The following is a description of a gene set: Any process that activates or increases the frequency, rate or extent of the chemical reactions and pathways involving a protein. Human Gene Set: GOBP_POSITIVE_REGULATION_OF_PROTEIN_METABOLIC_PROCESS species: Homo sapiens, and this is the list of marker genes: SH3D19, INHBA, SIRT1, HECTD1, RCHY1, FLOT1, C3, IL17D, PTPN1, RASSF5, ADAM9, PDCD10, PRR16, ADCYAP1, BAD, UCN, CDK5RAP1, FASTKD3, CARD9, SENP2 (SUMO specific peptidase 2), SLC25A37, SGSM3, BCL3, DDRGK1, EFNA1, RNFT1, PRELID1, CCNY, SH3BGRL, CDK5RAP3, TBC1D7, DIP2B, TENT5B (terminal nucleotidyltransferase 5B), PSMC5, LRP2, VCP, CAV1, CENPE, PTPN22, BIRC3, MAD2L2, BBS7, TNFSF15, DAB2, RNF41, APOE, CCL19, BARD1, IL1B, NFE2L2, AURKAIP1, ZNF268, EREG, SOCS4, LCP2, CDKN1A, DCUN1D2, EEF2, RBM4, PPIA (NCBI Gene Id 5478), KCNE2, ENO1, SLC51B, AKTIP, PROM2 (prominin 2), LACRT, COPS8, PRMT1, HSPA1B, ATG7, NGRN, DDR2, PRLR (NCBI Gene Id 5618), CDC20B, CSNK1D, PARP14, LPCAT1, ADIPOQ, SOX9, TNP2, SPRTN (SprT-like N-terminal domain), CSNK2A3, SNX1, ZER1, KDR, DIRAS1 (DIRAS family GTPase 1), VPS35, DAOA, BMAL1, RPS6KB2, USP16, FBXW8 (F-box and WD repeat domain containing 8), RAB7A, CTIF, RNF139 (ring finger protein 139), ENPP2, SNF8, MAP2K5, DAZ2, PSMD10, EIF4G1, DIP2A, KLKB1, CCL5, DNAJC3, COMMD1, CLSPN, PLD1, SMAD7, GGA1, ECSCR, FGFR1, METTL8, CREBRF, FXR1, EIF3E, MAP2K2, CAB39, AGO2, PXYLP1, TCIM (transcriptional and immune response regulator), METTL3, ABI1, RANBP9, DAZ3, KEAP1, PRICKLE1, TRAF6, NEK10 (NIMA related kinase 10), IL23R, OTUD6B, BARHL2, RSPO1, UPF3B, MAP3K4, JTB, PSEN1, ATP5IF1, RALB, IL21, RMND1, PIK3CG, TLR9, PIK3C3, FGFR3, RNF185, LDB1, DHX36, FAF1, VPS11, MAP2K1, BIRC7, ITCH, NCSTN, TNFRSF10A, USP13, ANGPT1, DTL, CSF1R, TNP1, CHFR, PTEN, PDCD6, MMP9, EGF, CIB1, VEGFB, ABCF1, SEC22B, STUB1, DHX29, KAT5, RASSF2, CTSC, ZCCHC4, MMD, PAXIP1, PIAS1, COP1, CNTN2, GCLC (NCBI Gene Id 2729), NLRC4, NSMCE3, SUMO2, MUL1, PICALM, APC, APP, SOCS5, TENM1, PLAUR, RAPGEF2, IFNGR1, PLK1, LIN28A, PAWR, ABCG1, SPSB4, ADAM8, PPP1R15A, FANCM, RAP2A, RIPK1, IL15, CACUL1 (NCBI Gene Id 143384), S1PR2, PSMC4, IDE, DAB2IP, ATXN3, CCR7, RIPK3, MAP3K7, SNX33, GBA1, CLU (NCBI Gene Id 1191), UBE2C, FBN1, TBC1D10A, EGLN2, CASS4, CCDC88A, MAGEC2, FBXL5, TARBP2, PLK2, NCK2, RNF111, PYM1, STOX1, UBE2D1, SIRT2, PLGRKT, DRD4, PDGFRB, TMEM259, EZR, LRRTM3, TIFAB, MARCHF7, MAPK9, CLN6, UBQLN2, SYAP1, CDKN1B, SMURF1, DVL1, DDX3X, LTF, MIF4GD, PHF23, RAB3GAP1, CTNNB1, OAZ3, ELAVL1, HSP90AA1, SERPINB3, SLC6A9, FOXO1, SOX17, FBXO33, IFNG, ZFAND2A, SORL1, PPP2R3A, CENPS, TANK, PINK1, CARD14, PIWIL2, KLF2, PIK3R5, KDM1A, STX5, BCL10, ERCC6, UBA2 (NCBI Gene Id 10054), TPD52L1, TNFAIP3, CBFA2T3, FBH1, RDX, MPV17L2, PABIR1, AGER, PASK, EFNA5, SPON1, UBE2K, CEBPA, CLIP3, MTA1, PTK2B, TNF, USP8, YBX3, TNFRSF1B, OGT, STK4, EIF2B5, FMR1 (NCBI Gene Id 5421), FZR1, MIR15B, ARL2BP, CREBL2, PRKDC, CARD10, ITGB1BP1 (integrin subunit beta 1 binding protein 1), TCF7L2, TBX1, MTPN, LILRA2, CPEB3, CHI3L1, DISC1, LIMCH1, TRUB2, NMI, RIPK2, EZH2, NEURL3, SAMD4A, PERP, TRMT10C, CALCA, NEDD4, RELA (NCBI Gene Id 5970), PCSK9, CD28 (NCBI Gene Id 940), IST1, PSMC2, MIURF, HPN, BIRC8, RBM3 (RNA binding motif protein 3), PDGFA, LARP4B, WNT5A, SP1, JAK2, CSNK1A1, IL33, SYK, MT3, MDM2, METTL14, STK11, CSNK2A1, EGR1 (early growth response 1), HDAC2, RAB3GAP2, ASPH, SVIP (small VCP interacting protein), MIR16-1, XIAP, NOP53, ISL1, IL11, BOLL, NDFIP1, DAZ1, PSMC1, VPS28, IL23A, SPRY2, MBP, AIMP2, PIBF1, PSMC3, MST1R, FANCI, BMP2, RAP1A, TNFSF12, FGFR4, PYHIN1, THPO, SEMG2, SEMA4D, PARP9, RHBDD3, IL6, LYN, LRRK2, AMER1 (NCBI Gene Id 160176), PTPRC, IL17F (NCBI Gene Id 112744), L3MBTL3, NKD1, OSM, BRAF, ARNT, ACVR2A, RAD23A, BAK1, CLEC3B, ARRDC3, FGF10, HSPA5, RAF1, SUMO1, PIAS4, MELTF, PCIF1, XBP1, CDC20, TRAF7, GSAP, TGFB1I1, C1QBP, ATG14, PLXNB2, CHRNA7, UPF3A, CBLB, HERPUD1, PLK3, HDAC4, PTK2, FGF18, HNRNPU, MYCBP2, S100A12, CDKN2A, RNF128, RARRES2, AKT2, BMP4, ANXA2, DDA1, CRIPTO, TNFRSF18, POLDIP3, USP5, EIF5A2, GAS6, FAM20A, EIF5AL1, SMYD5, UHMK1, EPHA4, GABARAP, GNL3, BMI1, PKP1, ABCB10, UBQLN1, CCBE1, FAM161A, THBS4, RALBP1 (ralA binding protein 1), GSK3A, CENPX, CR1, NRDC, HABP4, ARHGEF5, DOK7, FBXO4, PEF1, GRN, FXR2, SPDYA, PIK3R6, SEPTIN4, ZC3H12A, PSMC6, AGBL4, LAT, CD74, KIF14, OAZ1 (ornithine decarboxylase antizyme 1), MARCHF2, DCUN1D3, TLR6, RWDD3, SLC2A10, VIP, FLT1, C4BPA, MIR181B1, TRIB3, FASTKD2, MAPK8, PIAS3, TRIB1, RPUSD3, RAMP1, NIBAN1, EGFR, HUWE1, ARRDC4, BANK1, ELOB, SH3RF1, IER3, TNFRSF10B, IL31RA, RCC1L, PLA2G10, TSPYL5, CSDE1, ARAF, DCUN1D4, DERL1, ASTL, RPS6KB1, ADCY8, PFN2, CD4, RASSF1, DHX9, ERBB2, HDAC3, YTHDF2, CRY1, PIM1, LEP (NCBI Gene Id 3952), PAIP1, NUB1, SNX9, CUL4A, ENSG00000293600, SRCIN1, RPUSD4, AURKA, BCAP31, ETAA1, NSF, DCUN1D1, TIPARP, IL12A, RHBDD1, NDUFA13, NAT10, PABPC1, POLR2G, WFS1 (NCBI Gene Id 94141), MAP2K3, FAM107A (NCBI Gene Id 50803), SKP2, SPHK1, RAC1, PILRB, FLT4, DAZ4, FAXDC2 (fatty acid hydroxylase domain containing 2), EFNA3, ITGA2 (NCBI Gene Id 3673), MSN, WDFY2, MIR206, ZFP91, UNC119, INAVA, ABCA2, TAF1 (NCBI Gene Id 6872), NOD2, TOLLIP, SH3RF3, ARHGEF2, CHP1, NCK1 (NCBI Gene Id 4690), TRIM6, CSF1, AXIN1, SYNCRIP, CAPN3, RIGI, FBXW7, FURIN, NUPR1, TRIM67, BRMS1, IFNL1, LARP4, RASD2, FGF1, LILRA5, FGF2, ASB9, OAZ2 (ornithine decarboxylase antizyme 2), MAP3K11, ABL1, RGMA, TNFSF18, DIPK2A, AXIN2, THBS1, CAMK1, MTOR, PRKN, KNDC1, MYDGF, WNT7A, MAP3K5, HLA-DRB1, CCL21, PKM, BTRC, RCN3, CUL3, BAG6, PLCB1, TMX1, IRGM, ROCK2, CAV3, ADRA2A, RPL26, CIRBP, DET1, CCDC22, PRKCD, CNTF (NCBI Gene Id 1270), ITLN1, EIF4G3, UBE3A, PIN1 (peptidylprolyl cis/trans isomerase, NIMA-interacting 1), DNAJA3, YTHDF3, CD81, FBXO22 (F-box protein 22), MMD2, PAQR3, SH3RF2, CSPG4, UBXN2A, RBMS3, NKD2, KIT, CASP8, SEMG1, NGF, TFR2, PAEP, CASP3, OSBPL7, RNFT2, UBR3, RASGRP1, GPRC5B, MAPK7 (mitogen-activated protein kinase 7), EIF3C, UFL1, SRC, METTL5, TGFB1, UBE2S, ASB5, DACT1, KHDRBS1 (NCBI Gene Id 10657), KLHL40, SERP1, IGF2BP1, NPM1 (NCBI Gene Id 4869), GPLD1, UBE2N, IL18, IGF1, TXN, WNK3, XRCC6, MMP14, ATXN3L, AKT1, AGAP2 (ArfGAP with GTPase domain, ankyrin repeat and PH domain 2), PDGFB, UBB, CTF1, TNIP1 (NCBI Gene Id 10318), FLT3, LRP1, CSNK1E, JMJD4, MAGEA2B, DYNAP, IL12B, RPS27L, ALS2, BRAT1, LARP1, TRAF4, MAPK1, VGLL4, TMTC3, VEGFA, ADAM17, RHOA, DIRAS2, PRKCH, HNRNPD, SSB, LARP1B, EIF2AK4, MYH9, MRNIP, HMGA2, IKBKG, DAZL (deleted in azoospermia like), SOAT1, PELI2, BAG2, COA3, UBE2L3, ODAM, FGF19 (fibroblast growth factor 19), CNOT9, F12, HAMP, CDC14B, TAB2, IL20, ELANE, EIF6, AGTPBP1, SLC2A13, MUSK, TRIB2, UQCC2, SASH1, ZCCHC13, NHLRC1, ERN1, NNMT (nicotinamide N-methyltransferase), RFPL1, ERBB4, VSIR, MAGEA2, YTHDF1, GPC3, HSPA1A, STRADB, SKP1, UBE2V2, XRCC5, TAOK3, STRADA, LIF, CFL1, NDFIP2, WBP1L, CD80, RPL5, TNK2, LAPTM5, EIF5A, TF, MYLIP, IL34, NEDD4L (NEDD4 like E3 ubiquitin protein ligase), EIF4A3, FBXW11, PIH1D1, CEP295, ANGPTL8, CNBP, PTTG1IP, SIRT6, C4BPB, GGA3, TOM1L1, ASB11, RACK1, PACSIN3, TNIK, MUSTN1, GSN, MAP4K2, RBX1, FADD, ARRB1, GPER1, LDLR, TRIM32, DCAF1, ZYG11B, HSPBP1, RPS2, CYFIP2, DNAJB2, HES1, MALT1 (MALT1 paracaspase), YBX1, RILP, CD86, GUF1, GSK3B, UHRF1, TICAM1 (TIR domain containing adaptor molecule 1), DCUN1D5, CUL4B, MAP3K10, ECT2, TPX2, ASPSCR1, SGTA (small glutamine rich tetratricopeptide repeat co-chaperone alpha), PRSS22, TLR3, NSUN5, CEMIP, RNF180, ANGPT4, KLF4, SAE1 (SUMO1 activating enzyme subunit 1, NCBI Gene Id 51502), BIRC2, PELI1, NPTN, NEDD9, TRAF2, RPS4X, NRG1, TREM2, RAB1B, KRT17, DDB1, GOLGA2, RAB1A, FGF7, S100A10, UBE2V1, PSENEN, CDK2AP1